Given this list of marker genes MTTP (microsomal triglyceride transfer protein), SAR1B, CCT5, APOC3, NGLY1, GALNT2, ANGPTL3, ACOX2, PCYT1A, here is a description of the gene set: Hypolipidemia Human Gene Set: HP_HYPOLIPIDEMIA studied in species Homo sapiens